The following is a description of a gene set: Abnormal urinary nucleobase concentration studied in species Homo sapiens Human Gene Set: HP_ABNORMAL_URINARY_NUCLEOBASE_CONCENTRATION A deviation from the normal level of a nucleobase in the urine. Nucleobases are nitrogen-containing biological compounds that form nucleosides: adenine (A), cytosine (C), guanine (G), thymine (T), and uracil (U)., and this is the list of marker genes: MOCS2, PNP, SLC28A1, CHUK, MOCOS, APRT, DPYD, ATIC, ADSL, MOCS1, SLC25A21 (solute carrier family 25 member 21), DPYS